The following is a description of a gene set: species: Mus musculus Mouse Gene Set: GOBP_TRIGLYCERIDE_MOBILIZATION The release of triglycerides, any triester of glycerol, from storage within cells or tissues, making them available for metabolism., and this is the list of marker genes: Sirt1, Lpin1 (lipin 1), Il6st, Apob, Apoc3, Slc27a5